The following is a description of a gene set: Mouse Gene Set: GOBP_DESMOSOME_ORGANIZATION A process that is carried out at the cellular level which results in the assembly, arrangement of constituent parts, or disassembly of a desmosome. A desmosome is a patch-like intercellular junction found in vertebrate tissues, consisting of parallel zones of two cell membranes, separated by an space of 25-35 nm, and having dense fibrillar plaques in the subjacent cytoplasm. studied in species Mus musculus, and this is the list of marker genes: Prkca, Nectin1, Dsg2, Pkp2, Grhl1, Dsp, Pkp1, Dsg3, Cdh1, Kprp, Perp, Jup, Pkp3, Snai2, Dsc1